Given this list of marker genes DNAJB11, USP8, RPS20, PMS2, KDM1A, CDKN2B, BMPR1A, GANAB, CDH23, EPCAM, TP53, CDKN2C, PDE11A, MSH6, CHEK2, BRAF, ALG5, PMS1, ARMC5, BRCA2, MUTYH, IFNG, PIK3CA, PRKAR1A, MEN1, CDKN1B, IDH2, PKD2, PKD1, IFT140, GNAS, IDH1, USP48, GPR101, APC, TSC1, TSC2, MSH2, CDKN1A, ALG9, MLH1, AIP, ATM, NR3C1, POLD1, POLE, KRAS, YY1, SEMA4A, BICC1, ATRX, TGFBR2, here is a description of the gene set: Human Gene Set: HP_PITUITARY_ADENOMA A benign epithelial tumor derived from intrinsic cells of the adenohypophysis (anterior pituitary). species: Homo sapiens Pituitary adenoma